The following is a description of a gene set: species: Homo sapiens Difficulty climbing stairs Human Gene Set: HP_DIFFICULTY_CLIMBING_STAIRS Reduced ability to climb stairs., and this is the list of marker genes: KBTBD13, CAPN3, POMGNT1, POMK, MIEF2, GFPT1, SGCD, TWNK, LMNA, MFN2, DNAJB6, RYR3, DMD, MYH7, PLEKHG5, DYSF, VMA21, LIPE, HADHB (NCBI Gene Id 3032), PLEC, LRP12, FLNC, WDR62, VCP, DAG1, ADSS1, PYROXD1, ALG2, MYOT, SNUPN, MT-TE, DPAGT1, PHKA1, DNA2, ALG14, PHKG1, TOR1AIP1, HADHA, RYR1, RRM2B, TPM3, ANO5, SLC25A4, FKRP, GAA, TNPO3, SGCG, LAMA2, LRIF1, COL6A1, ACTA1, POLG, RNASEH1, POLG2, MEGF10, BIN1, TCAP, TPM2, POMT1, TFG (NCBI Gene Id 50989), GMPPB, POMT2, MYPN, TNNT1, SPTAN1, SPEG, VAPB, TTN, SGCA